The following is a description of a gene set: The chemical reactions and pathways involving monoacylglycerol, any ester of glycerol in which any one of its hydroxyl groups has been acylated with a fatty acid, the other being non-esterified. studied in species Mus musculus Mouse Gene Set: GOBP_MONOACYLGLYCEROL_METABOLIC_PROCESS, and this is the list of marker genes: Dgat2, Abhd16b, Dgat1 (diacylglycerol O-acyltransferase 1), Pla2g4a, Mgll, Awat2, Abhd16a, Abhd12b, Dgat2l6, Abhd6, Mogat2, Daglb, Abhd12, Faah, Dagla